Given this list of marker genes CD19, CD79B (NCBI Gene Id 974), VMO1 (vitelline membrane outer layer 1 homolog), P2RX5, PCDH9, MS4A1, TSPAN13, FCRL1, NIBAN3, PAWR, LARGE1, SETBP1, FCRL2, CD22, BANK1, RUBCNL, EBF1, CD72, CNR2, FCRLA, FCER2, here is a description of the gene set: from publication Sobolev O, Binda E, O'Farrell S, Lorenc A, Pradines J, Huang Y, Duffner J, Schulz R, Cason J, Zambon M, Malim MH, Peakman M, Cope A, Capila I, Kaundinya GV, Hayday AC (PMID 26726811) Adjuvanted vaccines afford invaluable protection against disease, and the molecular and cellular changes they induce offer direct insight into human immunobiology. Here we show that within 24 h of receiving adjuvanted swine flu vaccine, healthy individuals made expansive, complex molecular and cellular responses that included overt lymphoid as well as myeloid contributions. Unexpectedly, this early response was subtly but significantly different in people older than ~35 years. Wide-ranging adverse clinical events can seriously confound vaccine adoption, but whether there are immunological correlates of these is unknown. Here we identify a molecular signature of adverse events that was commonly associated with an existing B cell phenotype. Thus immunophenotypic variation among healthy humans may be manifest in complex pathophysiological responses. Genes up-regulated in peripheral blood mononuclear cell high vs low responders in adults (18-64) (medium-high adverse events score) after exposure to Pandemrix, time point 1D. Comment: Pre-vaccine transitional B cell levels and increased auto-antibodies correlate with post-vaccination AE. (a) Genes expressed differentially in low AE vs medium/high AE study subjects, both pre-vaccination and on post-vaccine days +1 and +7 species: Homo sapiens Human Gene Set: SOBOLEV_PBMC_PANDEMRIX_AGE_18_64YO_HIGH_VS_LOW_RESPONDERS_MEDIUM_HIGH_ADVERSE_EVENTS_SCORE_1DY_CORRELATED_WITH_TRANSITIONAL_B_CELLS_UP